The following is a description of a gene set: Human Gene Set: MASRI_RESISTANCE_TO_TAMOXIFEN_AND_AROMATASE_INHIBITORS_UP Genes up-regulated in derivatives of MCF-7aro cells (breast cancer) that developed resistance to tamoxifen or inhibitors of aromatase (CYP19A1). Acquired resistance to either tamoxifen or aromatase inhibitors (AI) develops after prolonged treatment in a majority of hormone-responsive breast cancers. In an attempt to further elucidate mechanisms of acquired resistance to AIs, MCF-7aro cells resistant to letrozole (T+LET R), anastrozole (T+ANA R), and exemestane (T+EXE R), as well as long-term estrogen deprived (LTEDaro) and tamoxifen-resistant (T+TAM R) lines were generated. This is the first complete panel of endocrine therapy-resistant cell lines, which were generated as multiple independent biological replicates for unbiased genome-wide analysis using affymetrix microarrays. Although similarities are apparent, microarray results clearly show gene signatures unique to AI-resistance were inherently different from LTEDaro and T+TAM R gene expression profiles. Based on hierarchical clustering, unique estrogen-responsive gene signatures vary depending on cell line, with some genes up-regulated in all lines versus other genes up-regulated only in the AI-resistant lines. Characterization of these resistant lines showed that LTEDaro, T+LET R, and T+ANA R cells contained a constitutively active estrogen receptor (ER)alpha that does not require estrogen for activation. This ligand-independent activation of ER was not observed in the parental cells, as well as T+EXE R and T+TAM R cells. Further characterization of these resistant lines was performed using cell cycle analysis, immunofluorescence experiments to visualize ER subcellular localization, as well as cross-resistance studies to determine second-line inhibitor response. Using this well-defined model system, our studies provide important information regarding differences in resistance mechanisms to AIs, TAM, and LTEDaro, which are critical in overcoming resistance when treating hormone-responsive breast cancers. from publication Masri S, Phung S, Wang X, Wu X, Yuan YC, Wagman L, Chen S (PMID 18559539) species: Homo sapiens, and this is the list of marker genes: ABCA12, TMT1A, ATRNL1, ELOVL2, FHL1, KLK11, RMST, MGP, SULF1, DMD, NPY1R, MYBL1, AGR2, GJA1, GREB1, AREG, PGR, CYP26B1, PDZK1, TFF1